Given this list of marker genes DNAI3, CTNNA2, CORO1B (coronin 1B), GMFG, GMFB, PICK1 (NCBI Gene Id 9463), HIP1R, here is a description of the gene set: Any process that stops, prevents, or reduces the frequency, rate or extent of actin nucleation mediated by the Arp2/3 complex and interacting proteins. Human Gene Set: GOBP_NEGATIVE_REGULATION_OF_ARP2_3_COMPLEX_MEDIATED_ACTIN_NUCLEATION studied in species Homo sapiens